Given this list of marker genes Nrgn, Atp1a3, Fus, Dnm3, Fmr1, Ppp1r1b, Srgap2, Rgs7bp, Gria2, Gper1, Hpca, Grip1, Ppp1r9b, Cacna1s, Drd1, here is a description of the gene set: Distal part of the dendritic spine, that carries the post-synaptic density. species: Mus musculus Mouse Gene Set: GOCC_DENDRITIC_SPINE_HEAD